The following is a description of a gene set: The purpose of this paper is to correlate the molecular phenotype of papillary thyroid carcinoma (PTC) to their biological pathology. We hybridized 26 PTC on microarrays and showed that nearly 44% of the transcriptome was regulated in these tumors. We then combined our data set with two published PTC microarray studies to produce a platform- and study-independent list of PTC-associated genes. We further confirmed the mRNA regulation of genes from this list by quantitative reverse transcription-PCR. Analysis of this list with statistical tools led to several conclusions: (1) there is a change in cell population with an increased expression of genes involved in the immune response, reflecting lymphocyte infiltration in the tumor compared to the normal tissue. (2) The c-jun N-terminal kinase pathway is activated by overexpression of its components. (3) The activation of ERKK1/2 by genetic alterations is supplemented by activation of the epidermal growth factor but not of the insulin-like growth factor signaling pathway. (4) There is a downregulation of immediate early genes. (5) We observed an overexpression of many proteases in accordance with tumor remodeling, and suggested a probable role of S100 proteins and annexin A2 in this process. (6) Numerous overexpressed genes favor the hypothesis of a collective migration mode of tumor cells. Genes up-regulated in papillary thyroid carcinoma (PTC) compared to normal tissue. Human Gene Set: DELYS_THYROID_CANCER_UP studied in species Homo sapiens from publication Delys L, Detours V, Franc B, Thomas G, Bogdanova T, Tronko M, Libert F, Dumont JE, Maenhaut C (PMID 17621275), and this is the list of marker genes: MXRA8, ACTN4, GGCT, GABRG3, GRB7, BIRC7, SNX1, BCAT1, CKS2, SPINT1, RASAL2, LOXL2, RAMP1, B3GAT1, CRYBG1, LCN2, FAP, MS4A6A, BICD1, ALDH1A3, IGSF3, DSC2, SLC16A4, TNFRSF10C, ENTPD1, G0S2, LGALS1, PROS1, KCNK1, IL10RA, BID, BBLN, IL13RA1, PDLIM4, KLK6, TMSB10, LSR, CYBA, DMD, COL3A1, FXYD5, MPZL2, CLDN1, ATP1B3, SAMD4A, OPCML (opioid binding protein/cell adhesion molecule like), NAB2, GDF15, KCNQ3, HMGA2, ADM, ITGA2, CDH3, COL8A1, EVPL, RHOBTB3, S100A1, KRT15 (NCBI Gene Id 3866), TSPO, SEMA3F, DSP, MMP1, GALNT12, ANXA2, MET, ABR, ADK, PNP, DUSP5, AHNAK2, STX3, TUSC3, BMERB1, ITGB5, COL10A1, APLNR, CTSC, ACAA2 (acetyl-CoA acyltransferase 2), MDK, PCSK2, SDC1, MSR1, ALOX15B, EPHA4, MMP11, PLXNB2, NRCAM, CTSD, TIPARP, NFE2L3, APOC2, ARMCX6, MYH10, TIAM1, NRIP1, TRPC5, PLPP2, ABCC3, RXRG, MAP4K4, ODC1, EPS8, SPP1, C1QB, DTX4, GALE, HEY2, FLII, HMOX1, RGS3, MAP4K1, FCGR2A, KRT19, DUSP6, SERPINA1, CCL18, CPD, CD44, GPRC5B, FMO5, PTK7, ACOT7, S100A5, SCG5, KRT6A, MBOAT2, LST1, ATP11A, MST1R, GFUS, RREB1, PTPRU, EPHA2, DDB2, MVP, SLC1A5, CYFIP2, SFTPB, APOE, PDLIM1, BCL9, IGF2BP2, APOC1, NMU, CBLN1, MAPK13, TRIM29, GLRB, PLAU, IL1RN, DHRS3, PC, KCNN4, PPP4C, SYNGR2, PXDN, ETHE1, TACSTD2, PAPSS1, WARS1, KDELR3, FN1, LIF, ENC1, PLXNB1, IGFBP3, CHIT1, SLPI, CFB (complement factor B), KRT13, RDH5 (retinol dehydrogenase 5), GPX1, NELL2, MAP3K5, EMILIN2, COL13A1, INHBB, CYP1B1, ITPR3, GJB3, PKM, C1orf115, APLP2, TP53I3, LGALS3, GJA4, RAB27A, THBS1, LAMC2, ETV1, ATP6V1B2, S100A10, MYO1D, PRDM1, HIP1, HAS2, TREM2 (NCBI Gene Id 54209), NCDN, ME3, PCDH7, PDZK1IP1, CKLF, SEL1L3, SV2A, AREG, PLXND1, AGR2, SLC6A1, FAS, GABBR2, LPL, FJX1, QSOX1, BHLHE40, TMC6, TGM2, PON2, LAMB3, ELF3, TRIM14, CLDN9, STAC, P4HA2, PRSS3, DPYD, MFGE8, SH3GL1, KLHDC8A, ABCC6, DPP4, CITED1, PTPRF, SLC6A14, THBS2, ST14, PLIN2, CTSH, CHI3L2, CDKN1A, ADGRE5, PLXNC1, KLK10, FLVCR2, CTSA, STAT1, ITGB7, SDC4, ICAM1, MEGF9, TIMP1, SLC7A5, EMP3, CLDN7, PLAG1, AGRN, TK1, MARCO, CRLF1, PLD3, IER3, ITGA3, SFN, RBBP8, TRIM22, TDO2, CTTN, TNC, SPOCK2 (SPARC (osteonectin), cwcv and kazal like domains proteoglycan 2), ARHGAP19, IFI30, YAF2, SH2D1A, CA11 (NCBI Gene Id 770), KCNK5, VCAN, PRSS2, PLAAT3, CD58, ANXA2P1, CAPG, TLR2, LY6E, UPP1, RNASE6, CCND1, QPCT, MPV17, NT5E, H2AC18, CDH2 (NCBI Gene Id 1000), ICAM4, TNFRSF10B, IGFBP6, FGF1, FSTL3, CEACAM6, RUNX1, H2AX, ALOX5, ETV5 (NCBI Gene Id 2119), BCL2A1, HPN, SLC22A18, PDE5A, CTSB, NPTX2, RPS6KA2, MUC1, MSMO1, TREM1, CLDN10, PMAIP1, SLC17A9 (NCBI Gene Id 63910), S100A4, TAX1BP3, MNDA, TNFRSF21, MFAP2, MAP2, C4A, HP, C3, EPHB3, ST3GAL5, DHCR7, NINJ1 (ninjurin 1), ALOX5AP, TNFRSF1A, STMN2, S100B, TM7SF3, COL1A1, CXCL2, PLK3, MMP7, NCKAP1L, ANXA8, MRC2, KRT14, SLIT1, ATP10B, COMP, ACY1, S100A2, CAMK2A, ADORA3, ECE1, MRC1, RYR1, MED13, MALL, DOCK9, CHI3L1, TMEM87A, S100A13, ALDH3B1, PHLDA2, PSD3, DAPK2, ROR1, PPL, CD55, CFI, NR1D1, INHBA, TPSB2, TNFAIP6 (NCBI Gene Id 7130), ECM1, CCND2, ANXA1, SOX4 (SRY-box transcription factor 4), KRT17, UBE2A, ADORA1, DUSP4, NMB, UCP2, PBX3, EREG, SCN1B, COL5A2, BMAL1, ITGA9, CSF1R, CD151, PRSS23, ELF4, ADAM12, S100A11, ARHGDIB, SPOCK1, CCL13, STAM, IGSF1, C2, IGSF6, COL11A1, CPA3, CCL17, LRP4, MAPKAPK3, TNFSF13, PTP4A3, CRABP2, VAMP8, CTSS, MAP3K6, CHST2, IL1RAP, LYN, NRP2, C1QA, RAD23B, ENDOD1, GBP2, MGRN1, ERBB3, SLC26A3, PASK, CXCL8, MLLT11, CORO1C, PTPRE (protein tyrosine phosphatase receptor type E), FYN, PTPRG, TNFSF15, CCR1, MTUS1, CD1A, ATIC, MYO6, RRAS, NPC2, TGFA, CX3CR1, PRAF2, SCEL, RCN2, CST6, MYEF2, PLCD1, C3AR1, DPYSL3, KLHL2, NCF2